Given this list of marker genes KIT, here is a description of the gene set: Regorafenib is a type II tyrosine kinase inhibitor that is approved for treatment of advanced gastrointestinal stromal tumors with KIT mutations. Regorafenib is effective in imatinib-resistant tumors carrying secondary mutations in exon 14 (gatekeeper mutation), and most KIT secondary mutations encoded by exons 17 and 18 (the activation loop). species: Homo sapiens part of: Drug resistance of KIT mutants Reactome Pathway: Regorafenib-resistant KIT mutants